The following is a description of a gene set: Human monoamine oxidases (MAOs) are flavin-containing enzymes that are present on the outer mitochondrial membrane and act on primary, secondary and tertiary amines. In contrast to the P450s which have a large number of isozymes, MAOs number only two isozymes, MAO-A and MAO-B. These gene products share over 70% sequence identity, are approximately 59KDa in size and have overlapping substrates (for example dopamine, tryamine and tryptamine) but each form also has distinct substrate specificities. MAO-A (primary type in fibroblasts) preferentially oxidises serotonin (5-Hydroxytryptamine) whereas MAO-B (primary type in platelets) prefers phenylethylamine. MAOs are of particular clinical interest because of the use of MAO inhibitors (MAOI) as antidepressants or in the treatment of neurodegenerative diseases Benedetti 2001, Beedham 1997). part of: Amine Oxidase reactions Reactome Pathway: Biogenic amines are oxidatively deaminated to aldehydes by MAOA and MAOB species: Homo sapiens, and this is the list of marker genes: MAOA, MAOB (NCBI Gene Id 4129)